The following is a description of a gene set: Mouse Gene Set: REACTOME_TP53_REGULATES_TRANSCRIPTION_OF_CELL_DEATH_GENES TP53 Regulates Transcription of Cell Death Genes species: Mus musculus, and this is the list of marker genes: Igfbp3, Zfp420, Casp2, Rabggtb, Prelid1, Atm, Tmem219, Rabggta, Bnip3l, Pidd1, Chm, Triap1, Prelid3a, Cradd, Steap3